Given this list of marker genes HEPACAM, FASLG, FAS, PIK3CA, CASP10, PTEN (NCBI Gene Id 8037), CDKN1B, MEN1, AKT1, CDC73, MSH3, here is a description of the gene set: species: Homo sapiens Thyroid adenoma Human Gene Set: HP_THYROID_ADENOMA The presence of a adenoma of the thyroid gland.